Given this list of marker genes PLEKHA8P1, MAG, GLTPD2, PLTP, CLIP3, MAP1LC3B (NCBI Gene Id 81631), SELP, LAPTM4B, EPDR1, LYN, PLA2G4A, CPTP, VDAC1, LAMB1, PSAP, LAMA1, SELL, GLTP (NCBI Gene Id 51228), CLN8, S1PR1, RTN4R, PHB2, CERT1, TRAF2, CERKL, IL2, PLEKHA8, CD300LF, VDAC2, here is a description of the gene set: Human Gene Set: GOMF_SPHINGOLIPID_BINDING studied in species Homo sapiens Binding to a sphingolipid, a class of lipids containing the long-chain amine diol sphingosine or a closely related base (a sphingoid).